The following is a description of a gene set: from publication Lim E, Wu D, Pal B, Bouras T, Asselin-Labat ML, Vaillant F, Yagita H, Lindeman GJ, Smyth GK, Visvader JE (PMID 20346151) Genes consistently down-regulated in mammary luminal progenitor cells both in mouse and human species. species: Mus musculus INTRODUCTION: Molecular characterization of the normal epithelial cell types that reside in the mammary gland is an important step toward understanding pathways that regulate self-renewal, lineage commitment, and differentiation along the hierarchy. Here we determined the gene expression signatures of four distinct subpopulations isolated from the mouse mammary gland. The epithelial cell signatures were used to interrogate mouse models of mammary tumorigenesis and to compare with their normal human counterpart subsets to identify conserved genes and networks.METHODS: RNA was prepared from freshly sorted mouse mammary cell subpopulations (mammary stem cell (MaSC)-enriched, committed luminal progenitor, mature luminal and stromal cell) and used for gene expression profiling analysis on the Illumina platform. Gene signatures were derived and compared with those previously reported for the analogous normal human mammary cell subpopulations. The mouse and human epithelial subset signatures were then subjected to Ingenuity Pathway Analysis (IPA) to identify conserved pathways.RESULTS: The four mouse mammary cell subpopulations exhibited distinct gene signatures. Comparison of these signatures with the molecular profiles of different mouse models of mammary tumorigenesis revealed that tumors arising in MMTV-Wnt-1 and p53-/- mice were enriched for MaSC-subset genes, whereas the gene profiles of MMTV-Neu and MMTV-PyMT tumors were most concordant with the luminal progenitor cell signature. Comparison of the mouse mammary epithelial cell signatures with their human counterparts revealed substantial conservation of genes, whereas IPA highlighted a number of conserved pathways in the three epithelial subsets.CONCLUSIONS: The conservation of genes and pathways across species further validates the use of the mouse as a model to study mammary gland development and highlights pathways that are likely to govern cell-fate decisions and differentiation. It is noteworthy that many of the conserved genes in the MaSC population have been considered as epithelial-mesenchymal transition (EMT) signature genes. Therefore, the expression of these genes in tumor cells may reflect basal epithelial cell characteristics and not necessarily cells that have undergone an EMT. Comparative analyses of normal mouse epithelial subsets with murine tumor models have implicated distinct cell types in contributing to tumorigenesis in the different models. Mouse Gene Set: LIM_MAMMARY_LUMINAL_PROGENITOR_DN, and this is the list of marker genes: Itga5, Scarf2, Kif3c, Sema3f, Hspb8, Kcnip3, Cers6, Epdr1 (ependymin related 1), Dst, Tbc1d9, Trim29, Plch2, Asph, Cux1